The following is a description of a gene set: Mouse Gene Set: HALLMARK_IL2_STAT5_SIGNALING studied in species Mus musculus from publication Howe DG, Blake JA, Bradford YM, Bult CJ, Calvi BR, Engel SR, Kadin JA, Kaufman TC, Kishore R, Laulederkind SJF, Lewis SE, Moxon SAT, Richardson JE, Smith C (PMID 30224793) Mouse genes annotated to HALLMARK_IL2_STAT5_SIGNALING based on orthology mappings provided by the Alliance Genome Consortium, and this is the list of marker genes: Cd48, Snx9, Batf, Tnfrsf18, Glipr2, Etfbkmt, Itga6, Nrp1, Pnp, Drc1, Cdc42se2, Amacr, Cish, Il10ra, Bcl2, Praf2 (NCBI Gene Id 97593), Plin2, F2rl2 (coagulation factor II thrombin receptor like 2), Cdkn1c, Twsg1, Capn3, Socs2, Ccnd3, Enpp1, Mxd1, Gbp3, Slc29a2, Cd44, Tnfsf10, Spp1, Cd81, Cst7, Irf6 (interferon regulatory factor 6), Tnfrsf1b, Hk2, Serpinb6a, Csf1, Tnfrsf8, Wls, Ager, Hycc2, Phlda1, Plpp1, Slc1a5, Igf1r, Ckap4, Cd86, Dcps, Gsto1, Cdc6, Ccnd2, Lrrc8c, Anxa4, Ahnak, Rhob, Ptch1, Fgl2, Gata1, Itih5, Rgs16, Emp1, Nt5e, Plagl1, St3gal4, Rhoh, Pim1, Swap70, Tgm2, Ahcyl, Cxcl10, Ltb, Rragd, Slc2a3, Tnfrsf9, Alcam, Casp3 (caspase 3), Traf1, Batf3, Tnfsf11, Etv4, Myo1c, Sh3bgrl2, Hopx, Tiam1, Maff, Gpx4 (NCBI Gene Id 625249), Muc1, Bmpr2, Eef1akmt1, Plscr1, Il1rl1, Ikzf4 (IKAROS family zinc finger 4), Rabgap1l, Irf4, Ctsz, Il1r2, Il4ra, Furin, Tnfrsf4, Rnh1, Serpinc1 (NCBI Gene Id 98260), Tlr7, Igf2r, Gucy1b1, Ikzf2, Aplp1, Lif, Umps, Eomes, Ifitm3 (NCBI Gene Id 66141), Smpdl3a, Bhlhe40, Galm, Klf6, Hipk2, Itgav, Gpr65, Eno3, Cd79b (CD79B antigen), Bmp2, Mapkapk2, Il2rb, Gadd45b, Ndrg1, Ccne1, Csf2, Bcl2l1, Odc1, Prkch, Sell, Map6, Ttc39b, Ifngr1, Snx14, Ncs1, Rora (RAR-related orphan receptor alpha), Lclat1, Il2ra, Gabarapl1, Nfil3, Uck2, Car2, Phtf2, Penk, Nop2, Huwe1, Ctla4, Tnfrsf21, S100a1, Cd83, Adam19 (ADAM metallopeptidase domain 19), Il13, Syngr2, Plec, Cdcp1, Coch, Nfkbiz, Ecm1 (extracellular matrix protein 1), Map3k8, Selp, Gpr83, Capg, Il18r1, Ncoa3, P4ha1, Pou2f1, Dennd5a, Ptger2, Spry4, Slc39a8, Ahr, She, Spred2, Il3ra, Icos, Irf8, Itgae, Pus1, Cyfip1, Socs1, Ccr4 (NCBI Gene Id 12773), Lrig1, Col6a1, Flt3l, Abcb1a, P2rx4, Dhrs3, Fah, Syt11, Il10, Ptrh2, Myc, Myo1e, Pth1r, Prnp, Arl4a, Pdcd2l, Xbp1, Scn9a